Given this list of marker genes Slc15a1, Abcc2, Slc25a40, Slc15a2, Abcc1, Slc25a39, Car2, Abcc4, Nherf1, Mgst1, Slc13a3, Cdh17 (NCBI Gene Id 56487), Slc26a6, Slc7a11, Abcb9, Slc15a3, Mfsd1, Slco1b2, Abcb10, Slco3a1, Slc15a4, Abcc5, Slc22a8, Gja1 (NCBI Gene Id 14609), here is a description of the gene set: studied in species Mus musculus Mouse Gene Set: GOBP_OLIGOPEPTIDE_TRANSPORT The directed movement of oligopeptides into, out of or within a cell, or between cells, by means of some agent such as a transporter or pore. Oligopeptides are molecules that contain a small number (2 to 20) of amino-acid residues connected by peptide linkages.